Given this list of marker genes SLAIN2, CXCL10, USP18, SOCS3 (NCBI Gene Id 9021), TRAF5, CPEB1, CYLD, LYAR, CD14, ID2, OR6A2, DUSP2, ORC1, EARS2, PEAK1, ACSL3, FOS, TRAF1 (TNF receptor associated factor 1), UBC, ATL2, CCL4, RIOX1, CCL7, CCRL2, CCNL1, NEDD1, SLAMF7, SLA, PHLPP2, PPP1R3D, BTG2, RNASE10, OSM, KAZN, NLGN1, ARL14EP, BCKDK, PCNX1, NUP153 (nucleoporin 153), SOWAHC, HBZ, FYB1, ELAVL4, TMED9, TMEM68, GOLIM4, VMP1, THEMIS, SELENOT, UBXN4, ZNF81, PTDSS1, EXT1, MPHOSPH8, MBD1, BAG4, NR5A1, PRM3, STIL, KDM4C, LUZP2, VWA2, GPD1L, IPO7, MAP4K3, HHEX, RALGAPA1, RYBP, RUSC2, IFNAR1, GPR174, EGR1, SUCLA2, CD44, KDM6B, PRSS45P, DUSP1, SYT16, ZNF280B, FAM118A, ITGB4, INPPL1 (inositol polyphosphate phosphatase like 1), JUNB, PPP1R15A, RGS1, TMEM102, NFKBIA (NCBI Gene Id 4792), ZFP36L1, SPRED2, IFI44L, CYFIP1, DUSP16, KDM8, ZC2HC1A, SMARCD3, MAP3K8, STRN, ST6GAL2, GABRG1, ATL1, CEBPB, BEND3 (NCBI Gene Id 57673), PIM1, NECAP1, SFXN4, PHLDA1, M6PR, NRIP1, ZNF654, DCP1A, TNFSF9, GGCX, DHX16, ZNF830, IER3, FSHB, NFKBIZ, FGFR1, HS2ST1, BICRA, CHRNA5, GPR15, LPL, CIZ1, EEIG1, SOS1, CXCL3, RP1, SCN3A, XYLB, NUP37, SLC26A1, TRIM47, INTS13, TAF11, NAA15, LRRC14, LRRTM4, LPAR2, ABCA4, ZNF777, THAP2, SIM1, PARP9, MFSD9, IGSF8, PSD, ANKRD7, HLA-G, AGT, BRD2, ENO4, PKD1, ZFP36, LRTM2, IER5, BCL9, KRI1, LMTK2, SGK1, MRFAP1L1, GPRIN2, GMCL1, TMEM229B, BAP1, MSL2, GDF15, FBLN5, DOP1A, GFPT1, ING2, ANLN, TNF, PRRT3, GADD45G, BRCA1, CPE, ABCB10, RNF139, AOC3, LYPD1, SNCAIP (synuclein alpha interacting protein), DNMT1, ELP4, STAG1, PRKD2, COLGALT2, CERCAM, RNF215, MFSD4B, ANKRD40, IER2, GORASP1 (golgi reassembly stacking protein 1), NEU1, ARHGEF39, ABCA13, RBM22, PDE4B, TMEM177, FST, here is a description of the gene set: The innate immune system is a two-edged sword; it is absolutely required for host defense against infection, but if left uncontrolled can trigger a plethora of inflammatory diseases. Here we used systems biology approaches to predict and validate a gene regulatory network involving a dynamic interplay between the transcription factors NF-κB, C/EBPδ, and ATF3 that controls inflammatory responses. We mathematically modeled transcriptional regulation of Il6 and Cebpd genes and experimentally validated the prediction that the combination of an initiator (NF-κB), an amplifier (C/EBPδ) and an attenuator (ATF3) forms a regulatory circuit that discriminates between transient and persistent Toll-like receptor 4-induced signals. Our results suggest a mechanism that enables the innate immune system to detect the duration of infection and to respond appropriately. studied in species Homo sapiens Human Gene Set: GSE14769_UNSTIM_VS_20MIN_LPS_BMDM_DN Genes down-regulated in comparison of unstimulated macrophage cells versus macrophage cells stimulated with LPS (TLR4 agonist) for 20 min. from publication Litvak V, Ramsey SA, Rust AG, Zak DE, Kennedy KA, Lampano AE, Nykter M, Shmulevich I, Aderem A (PMID 19270711)